Given this list of marker genes NUMA1, BIRC5, PPP2R1A, CDCA8, MAP10, KIF4B, INCENP, AURKB, KIF4A, PRC1, RACGAP1, KIF23, AURKC, KIF11, here is a description of the gene set: Human Gene Set: GOBP_SPINDLE_ELONGATION The cell cycle process in which the distance is lengthened between poles of the spindle. species: Homo sapiens